The following is a description of a gene set: Any process that stops, prevents or reduces the frequency, rate or extent of stem cell population maintenance. studied in species Homo sapiens Human Gene Set: GOBP_NEGATIVE_REGULATION_OF_STEM_CELL_POPULATION_MAINTENANCE, and this is the list of marker genes: SIN3A, HDAC1, SAP30L, HNF1B, SUDS3, RBBP7, SAP30, RBBP4 (RB binding protein 4, chromatin remodeling factor), ING1, ZNF706, BRMS1L, TET1, LOXL2, OGT, BRMS1, ARID4B, WNT9B, PAX8, PAX2, ARID4A, BMP7, MIR145, SAP130, ING2, HDAC2, SINHCAF